The following is a description of a gene set: A developmental process, independent of morphogenetic (shape) change, that is required for a hair follicle to attain its fully functional state. Mouse Gene Set: GOBP_HAIR_FOLLICLE_MATURATION studied in species Mus musculus, and this is the list of marker genes: Ptgs2, Wnt5a, Gsdma3, Trpc4ap, Dsg4, Ppard, Tgfb2, Myo5a, Fermt1, Gal, Nf1, Notch1, Cdh3, Mreg, Psen1, Ctnnb1, Rbpj, Psen2 (NCBI Gene Id 98295), Nom1, Wnt10b, Msx2, Krtap21-1, Nsun2, Trpv1, Akt1, Ctsl, Barx2, Ercc2